The following is a description of a gene set: species: Homo sapiens Central hypothyroidism Human Gene Set: HP_CENTRAL_HYPOTHYROIDISM A type of hypothyroidism due to an insufficient stimulation of an otherwise normal thyroid gland. Central hypothyroidism is caused by either pituitary (secondary hypothyroidism) or hypothalamic (tertiary hypothyroidism) defects., and this is the list of marker genes: SMC1A, CPE, FOXA2, SMARCB1 (SWI/SNF related, matrix associated, actin dependent regulator of chromatin, subfamily b, member 1), TMEM67, GAS1, BAP1, OTX2, RPL10, TRHR, EIF2AK3, IRS4, SMARCE1, AKT1, NDN, TSHB, SIX3, SUFU, GLI3, POU1F1, INSR, HID1, ROBO1 (roundabout guidance receptor 1), PTCH1, FOXH1, TERT, NEXMIF, FGFR1, PLCH1, HESX1, LHX3, TRAF7, AIP, LHX4, SMO, KATNIP, CTNNB1, OCA2, DMXL2, ZIC2, CRIPTO, GLI2, STAG2, LEP, GNAQ, RBM28, TGIF1, BRAF, SNRPN (NCBI Gene Id 6638), PCSK1, SIM1, PROP1, SETBP1 (SET binding protein 1), LEPR, DLL1, MEN1, POU3F4, CDH23, CDON, TBL1X, NF2, SHH, TRH, ARNT2 (aryl hydrocarbon receptor nuclear translocator 2), POMC, GPR101, PDGFB, PIK3CA, FGF8, MAGEL2, SOX3, NODAL, STIL, DISP1, NIN (ninein)